The following is a description of a gene set: Mouse Gene Set: GOBP_MITOCHONDRIAL_RNA_3_END_PROCESSING species: Mus musculus Any process involved in forming the mature 3' end of an RNA molecule transcribed from a mitochondrial genome; occurs in the mitochondrion., and this is the list of marker genes: Hsd17b10, Trnt1, Elac2, Trmt10c, Supv3l1, Angel2, Pnpt1, Mtpap